The following is a description of a gene set: Inflammation of the biliary ductal system, affecting the intrahepatic or extrahepatic portions, or both. Cholangitis Human Gene Set: HP_CHOLANGITIS studied in species Homo sapiens, and this is the list of marker genes: RFX5, IL36RN, DCDC2, DZIP1L, DOCK8, BCS1L, REL, KIF12, CD40LG, CIITA, ITCH, ABCD1, IFT140, PKHD1, MAP2K1, IGKC, BRAF, CLDN1, WDR35, RFXANK, IGHG2, RFXAP, IL21R, ABCB4, MED12, NRAS, BCAP31, XIAP